Given this list of marker genes TNNT1, OBSL1, GALNS, TWIST2, CTC1, ATP6V0A2, PEX5, CEP152, PIGO, MAN2B1, SF3B4, MASP1, PLK4, UFSP2, LUZP1, FGFR1, HSPG2, GLRA1, GPC3, VAMP1, SRCAP, BMP4, GAS1, MYO18B, GNPTG, TRPM3, TRAPPC2, DHODH, ATRIP, EIF4A3, ERGIC1, TWIST1, PEPD, COG6, ATR, TRAF3IP1, TGFB1, NPAP1, EVC, SPEG (NCBI Gene Id 729871), ARNT2, COL25A1, AXIN1, PDPN, TBX4 (T-box transcription factor 4), VPS37D, LIMK1, SKI, SLC10A7, MTX2, INPPL1, ACTA1, FOXH1, CBFB, HDAC6, ADAMTSL2, KMT2D, HK1, METTL27, GJA1, GDF5, IFT43, PIK3C2A, PIGY, SBDS, HIVEP2, BMPER, F8, FANCF, TCTN3, HDAC4, PNPT1, CENPE, B3GAT3, TRIP11, GTF2IRD2, KDM3B, APC2, GPHN, ZIC3, BICRA, ACP5, GNS, NXN, ATP1A3, LGI4, PWRN1, RAD51C, HOXA11, RPS6KA3, ATP6V1A, UBE3B, PTPN2, CHD4, PALB2, SETBP1, LONP1 (lon peptidase 1, mitochondrial), DCHS1, NIN, RFWD3, FANCG, DPYSL5, TFE3, FANCC, LEMD3, IDUA, COL27A1, KIAA0753 (NCBI Gene Id 9851), RNU4ATAC, GORAB, DYNC2I2, PLOD1, GMNN, SLX4, UNC80 (NCBI Gene Id 84540), BMP1, GPX4, MACF1, WDR26, PHLDB1, SLC25A1, DSTYK, FGFRL1, VPS35L, CLCN7, CUL7, PIK3CA, SNRPN (small nuclear ribonucleoprotein polypeptide N), SMARCA2, RETREG1, CAV1, PIGA, SRP54, VCP, MUSK, FANCE, VAC14, DYNC2I1, TGIF1, POMT1, CRIPTO, NEB, AGRN, TRAPPC11, DLK1, PGAP2, TPM2, PTPN22, IFT81, IFNGR1, SLC5A7, SIM1, PRKCZ, RAB23 (NCBI Gene Id 64438), SNAP25, POP1, CHRNG, NTRK1, CCN6, TGFB2, ELN, LMX1B, RNF13, NGLY1, SLC6A5, GARS1, TRPV4, TBL2, CHRM3, PHEX, GNPNAT1, GLI3, AP4M1, SMOC1, PAFAH1B1, CNOT3, TAF6, COL1A1, CLIP2, COL12A1, DYNC2LI1, PI4KA, HNRNPH1 (heterogeneous nuclear ribonucleoprotein H1), DHCR7, ATAD3A, ZC4H2, EP300, SPARC, VPS13B, ZNF407, HNRNPR, LRP1, OSGEP, MKKS, WDR35, SATB2, FHL1 (NCBI Gene Id 2273), DDRGK1, GEMIN4, SLC2A10, SH3PXD2B, EXOC6B, KDM6A, IRX5, SMARCAL1, USP7, PTCH1, MBTPS1, SLC6A9, ATP6V1E1, LMNB2, SEC23A, NSD1, PPP2R5D, STIL, IL6ST, POMT2, EBP, SNORD115-1, SLC39A13, ATN1, CEP85L (centrosomal protein 85 like), IHH, HYAL1, PRKACA, TRAIP, IL2RA (NCBI Gene Id 3559), COL2A1, COLEC10, HACE1, CD247, MATN3, RAD21, PRG4, ACVR1, TMEM53, THOC2 (THO complex subunit 2), GLE1, IFIH1, MBTPS2, UBA1, COL3A1, IRF5, RSPRY1, COL9A1, MMP2, RIPK4, FANCB, FBLN5, PRDM16, COL5A1, COL11A1, PPP2R3C, LMOD3, CCDC47, COL5A2, PRKACB, MAP3K20, FGFR2, GLRB (NCBI Gene Id 2743), DNAJC21, IFT172, SOX9, SEC31A, ADA, ZNF469, EFEMP2, MED12, OSTM1, UBA2, CLTCL1, COL6A3, FREM2, SCYL2, BUD23, PLCB3, TAF1, PORCN, AFF4, CEP120, DVL3, COL13A1, MECOM, FANCD2, MYH8, MYO9A (NCBI Gene Id 80251), FBN2, FIG4, RAB11B, NSDHL, VPS33B, KLHL41, MEG3, ZBTB20, RPS15A, NIPBL, EIF2AK3, MYBPC1, ZFX, OCA2, HEATR3, LAMA5, WDR19, AP3B1, RAD51, MYL2, THRA, BRCA2, HNRNPK, FLI1 (NCBI Gene Id 2313), GUSB, WNT3, BAP1, PPP2R1A, DYM, BRCA1, B2M, GPC4, LGI3, CSGALNACT1, MMP9, AARS1, ARSK, MAP3K7, MCTP2, PTH1R, PWAR1, SELENON, TBXAS1, CDCA7, LRP4, NELFA, COLEC11, MBD5, DDB1, NDN, MAGEL2, FGFR3, KIF1A, PCNT, PIGN, TRIM8, CANT1, AP4E1, SLC35D1, ATAD1, POR, TET3, POC1A, RBBP8, IFT140, ITGA7, PIGL, FLNB, MMP13 (NCBI Gene Id 4322), CCR6, SCN4A, CHAT, COL9A2, FILIP1, KANSL1, ROR2, COG1, DISP1, FBLN1, TBCD, FKBP10, TOR1A, HLA-B, RAB33B, LYSET, RMRP, ALG9 (NCBI Gene Id 79796), KIF22, ECEL1, KCNK4 (NCBI Gene Id 50801), CHST3, EIF4H, TBX15, DYNLT2B, STAG2, ERCC8, SLC12A2, COL10A1, GET4, NODAL (nodal growth differentiation factor), TELO2, SOST, TNFRSF1A, AKT1, AFF3, ZMPSTE24, SHH, CTCF, MKRN3, SERPINF1, PYCR2, SYT2, FANCA, PIGV, PLCH1, CRELD1, SEC24D, XYLT1, HPRT1, VANGL1, ERCC6, GABRD (NCBI Gene Id 2563), B3GALT6, SIX3, OCRL, VIPAS39, CTBP1, KCNAB2, BRIP1, NSD2, CDON, ATP7A, PTRH2, SMAD4, FRAS1, SHOX, FGF8, RERE (arginine-glutamic acid dipeptide repeats), CCN2, SLC18A3, CLCN3, MYL1, SLC35A3, IDH1, SH3TC2, LMNA, ERCC4, PYCR1, IFT80, ANKRD55, FLNA, INTU, FUT8, PRDM5, COL1A2 (collagen type I alpha 2 chain), TTN, GLI1, EXT1, RBM8A, IPO8, SPEN, LETM1, COL6A2, ADAMTS2, BRD4, CCDC8, BIN1, AP4B1, UMPS, NANS, LTBP1, GMPPB, SMAD3, PCYT1A, CCBE1, FBN1, FUZ, WASHC5, CPLX1, COX8A, GSC, PPIB (NCBI Gene Id 5479), NFATC2, RTL1, GNPTAB (NCBI Gene Id 79158), HLA-DRB1, HERC2, FAT4, HACD1, STAT4, GLB1, ANKRD11, GRIP1, GJB2, UNC45A, SIX1, SMC3, RUNX2, P4HTM, AHDC1, PHF6, GNPAT, NKX3-2, PRIM1, SIK3, B3GLCT, BMPR1B, SNRPB, PLEKHM1, EXTL3, FN1, RAP1B, TRAPPC12, MMP23B, NALCN (sodium leak channel, non-selective), WNK1, HS2ST1, CD96, DMP1, KIAA0586, TMEM67, AEBP1, ANTXR1, PHIP, SIL1, C12orf57, CFL2 (cofilin 2), STX1A, FZD2, DVL1, ARX, PIGG, AP4S1, RYR3, DLL1, SCN9A, FKBP6, WNT7A, PUF60, WNT5A, USP9X, RSPO2, RFC2 (replication factor C subunit 2), CFAP410, IFITM5, FARS2, SNORD116-1, COL6A1, IL2RB, GNB2, NEPRO, XRCC2, NFIX, HHAT, LBR, ERLIN2, GTF2IRD1, RYR1, MYL11, TGFBR2 (NCBI Gene Id 7048), TONSL, KIAA0319L, RECQL4, CTSK, EED, NAA10, ABCC9, ALDH18A1, SMC1A, ORC1, COL9A3, YWHAE, GJB6, TPM3, DYNC2H1, EVC2, GLI2, TMEM270, SLC26A2, NCF1, ERI1, CRTAP, CSPP1, TNNT3, PIEZO2, MYH3, CREBBP, PAM16, EXT2, LARGE1, AIFM1, ABCC6, RINT1, EBF3, POLR3A, SHROOM4, SHPK, IDS, DNAJC30, ANKH, APC, CCDC22, VDR, GTF2I, TRPS1, POLR3B, DNA2 (NCBI Gene Id 1763), PIGW, COL11A2, POLR1A, IARS2, FANCM, TIMM22, PGAP3 (NCBI Gene Id 93210), BAZ1B, RPS19, BGN, IFT52, CASZ1, TNNI2, GNAS, FKRP, NUP85, COMP, HDAC8, ENPP1, TTC21B (tetratricopeptide repeat domain 21B), AMER1, BPNT2, SLC35A2, LRP5, EXOSC3, MAD2L2, SMO, DDR2, MYH7, ARSB, CENPJ, EYA1, LIFR, UBE4B, KAT6B, ERCC1, EZH2, ZIC2, UBE2T, BICD2, NRCAM, FANCL, MRPS25, VPS33A, FANCI, here is a description of the gene set: An abnormality of the bony pelvic girdle, which is a ring of bones connecting the vertebral column to the femurs. studied in species Homo sapiens Abnormal pelvic girdle bone morphology Human Gene Set: HP_ABNORMAL_PELVIC_GIRDLE_BONE_MORPHOLOGY